The following is a description of a gene set: studied in species Mus musculus Mouse Gene Set: GOBP_REGULATION_OF_DOUBLE_STRAND_BREAK_REPAIR_VIA_NONHOMOLOGOUS_END_JOINING Any process that modulates the frequency, rate or extent of double-strand break repair via nonhomologous end joining., and this is the list of marker genes: Dek, Smchd1, Kmt5b, Shld3, Pnkp, Usp51, Ercc6, Parp3, Top2b, Rif1, Mrnip, Aunip, Pot1a, Nsd2, Was (Wiskott-Aldrich syndrome), Shld2, Kmt5c, Prkdc, Pot1b, Cyren, Nudt16l1, Mre11a, Mad2l2, Hmga2, Hsf1, Fh1 (NCBI Gene Id 14194), Wrap53, Setmar, Actr2, Shld1, Kdm4d